Given this list of marker genes NRP2, RAP2C, NR2E1, GLIPR1, ANKRD28, GABRE, HAPSTR1, RAP1B, GRIA4, WDR48 (WD repeat domain 48), DMXL2, PDZRN4, CNEP1R1, SKIL, RAC1, OTUD4, BMPR1B, RHOQ (ras homolog family member Q), KDM1B, STX11, POGLUT3, STOX2, FBXO21, RFTN1, HK1, PCDH10, PXN, HADHB, GHR, GABRB2, CHMP2B (charged multivesicular body protein 2B), COMMD3-BMI1, PFN2, R3HDM1, H6PD, PPP3CA, MGA, FDX1, TAB2 (TGF-beta activated kinase 1 (MAP3K7) binding protein 2), ZNF474, HTR3A, AFF4 (NCBI Gene Id 27125), DAAM1, MASP1, SUB1, SLF2, N4BP2L1, CDKN2B, RAB25, MGAT4A, SMARCE1, BCORL1, MAPRE1, MRTFB, CYYR1, DHX9, AKIRIN2 (NCBI Gene Id 55122), NEXMIF, BEND4, RTL6, POC1B-GALNT4, GALNT4, C12orf42, RALGPS1, FUT8, NR3C1, DEDD (NCBI Gene Id 9191), LRRC18, PDS5B, PRKAR1A, CUX2, TMED7-TICAM2, SLC23A3, here is a description of the gene set: from publication Chen Y, Wang X (PMID 31504780) Genes predicted to be targets of miRBase v22 microRNA hsa-miR-1256 in miRDB v6.0 with MirTarget v4 prediction scores > 80 (high confidence targets). Human Gene Set: MIR1256 studied in species Homo sapiens